The following is a description of a gene set: Human Gene Set: GOBP_POSITIVE_REGULATION_OF_SEQUESTERING_OF_CALCIUM_ION Any process that activates or increases the frequency, rate or extent of the binding or confining calcium ions such that they are separated from other components of a biological system. studied in species Homo sapiens, and this is the list of marker genes: MTLN, GSTO1, FKBP1B, RYR2, NTSR1, TGFB1, CALM2, CALM1 (NCBI Gene Id 801)